The following is a description of a gene set: studied in species Mus musculus Mouse Gene Set: GOCC_PRESYNAPTIC_ENDOCYTIC_ZONE_MEMBRANE The region of the presynaptic membrane that is part of the presynaptic endocytic zone - where synaptic vesicles are endocytosed and recycled following release., and this is the list of marker genes: Cltb, Fcho2, Pip5k1c, Ap2s1, Dnm1, Ap2m1, Ap2b1, Dnm1l, Picalm, Cltc, Snap91, Clta, Dnajc6, Ctbp1